The following is a description of a gene set: LGI-ADAM interactions species: Mus musculus Mouse Gene Set: REACTOME_LGI_ADAM_INTERACTIONS, and this is the list of marker genes: Lgi1, Adam23, Stx1b, Lgi2, Cacng4, Cacng3, Dlg4, Lgi4, Stx1a, Cacng2, Lgi3, Cacng8, Adam22, Adam11